Given this list of marker genes FLNA, CSF1R, TNFSF11, SOST, SETBP1, TGFB1, TNFRSF11A, ANO5, GNAS, CA2, MTAP, STX16, here is a description of the gene set: Increased density of long bones An abnormal increase in the bone density of the long bones. species: Homo sapiens Human Gene Set: HP_INCREASED_DENSITY_OF_LONG_BONES